Given this list of marker genes Cfap206, Tacr1, Rnase10, Rnase9 (ribonuclease, RNase A family, 9 (non-active)), Tppp2, Prdm14, Eppin, Rgn, Cfap69, Iqcf1, Wfdc6a, Tac4, Tac2, Spinkl, Or4m1, Tacr2, Clxn, Ccr6, Tex101, Defb1, Tacr3, Wfdc6b, Adam7, Tac1, Defb37, Irgc, Kif9, Anxa5, here is a description of the gene set: species: Mus musculus Mouse Gene Set: GOBP_REGULATION_OF_FLAGELLATED_SPERM_MOTILITY Any process that modulates the frequency, rate or extent of flagellated sperm motility.